Given this list of marker genes Tet2, Mybl2, Nf1, Bub1b, Blnk, Notch1, Nrbp1, Smap1, Hmga1, Trp53, Bap1, Myc, Tnfrsf13b, Tusc2 (NCBI Gene Id 93800), Il15, Mir22, Phf6, Etv6, Asxl1 (ASXL transcriptional regulator 1), Arid4a (AT-rich interaction domain 4A), Kit, Cebpa, Hr, Kmt2a, Ctsg, Dicer1, Tal1, Rad50, Ezh2, Braf, Ptpn11, Nabp2, Crebbp, Ikzf1, Tgfbr2, Pten, Fli1, Samd9l, Rbm15, Cntn2, Atm, Gpx7, Spi1, Ncstn, Soat1, here is a description of the gene set: from publication Motenko H, Neuhauser SB, O'Keefe M, Richardson JE (PMID 26092688) Mouse Gene Set: MP_INCREASED_LEUKEMIA_INCIDENCE studied in species Mus musculus Mouse genes annotated to increased leukemia incidence (MP:0002026) retrieved from the Mouse Genome Informatics database via MouseMine